Given this list of marker genes Aldh3b1, Scd1, Gm15722, Runx1, Bahcc1, Csgalnact2, Sec14l1, 5430435K18Rik, Adam19, Ppp2ca, Ltbp1, Rapgef3, Gm26535, Mogat1, Sdc4, Mpzl1, Rpl13a, Trim45, Scd4, Sec61bl, Micos13, Lrp1, Uqcr11, Mrps12 (mitochondrial ribosomal protein S12), Smad3 (SMAD family member 3), Cnpy3, Rdm1, Mir6407 (NCBI Gene Id 102465220), Arfip1, 4930580E04Rik, C1qtnf1, Dnajb4, Glt28d2, Nrdc, Thbs1, here is a description of the gene set: studied in species Mus musculus from publication Yevshin I, Sharipov R, Kolmykov S, Kondrakhin Y, Kolpakov F (PMID 30445619) Mouse Gene Set: SIX6_TARGET_GENES Genes containing one or more binding sites for (Six6) in their promoter regions (TSS -1000,+100 bp) as identified by GTRD version 20.06 ChIP-seq harmonization.